The following is a description of a gene set: from publication Chen Y, Wang X (PMID 31504780) studied in species Mus musculus Mouse Gene Set: MIR_7688_5P Genes predicted to be targets of miRBase v22 microRNA mmu_miR_7688_5p in miRDB v6.0 with MirTarget v4 prediction scores > 80 (high confidence targets)., and this is the list of marker genes: Cdk5rap3, Caln1, Nuf2, Sorbs3, Cbfa2t3, Plk3, Exo1, Tln1, Slc9a4, Mob3a, Sfrp2, Nfasc, Epb41l1, Syt6, Loxl2, Parp14, Scn4b, Galnt6, Nol12, Bgn, Nr2c2, Serpinb8, Zfp654, Dgkk, Stx16, Pla2g4b, Cyp2c40, Pcdh7, Gpr3, Ankrd33, Atcay, Prpf4, Siae, Erfe, Vmn1r65, Szrd1, Cdc42bpa, Csad, Abr, Tnfaip1, Tbl1xr1, Ift52, Ldlrap1, Nfic, Atg9a, 5730455P16Rik, Mrpl35, Golga1, Sirpa, Ccdc137, Naa50, Nudt13, Phf8, Grsf1, Ptrh2, Med26, Vmn1r58, Trank1, Igf2bp3, Adgrf5, Ulk1, Arid1a, Pdxp, Sfxn4, Kcna6, Col27a1, Clcnka, Sidt2 (SID1 transmembrane family, member 2), Vti1a, Cyp2c67, Rspo4, Fam217a, Nipsnap2 (nipsnap homolog 2), Nfatc4, Rfng, Dpysl3, Wnt2b, Hsf2, Rab11b, Nav1, Padi1, Slc15a1, Scgb3a1, Gga3, Sema3g, Cdc37l1, Adcyap1r1, Erlin1, Cpeb1, Ppp5c, Macrod1, Sh3gl1, Csf1r, Itpripl2, Ncoa1